Given this list of marker genes Chrna4, Chrna7, Chrne, Chrnb2, here is a description of the gene set: part of: Neurotransmitter receptors and postsynaptic signal transmission studied in species Mus musculus electronically inferred by orthology from the curated human pathway Reactome Pathway: Acetylcholine binding and downstream events This event has been computationally inferred from an event that has been demonstrated in another species.<p>The inference is based on the homology mapping from PANTHER. Briefly, reactions for which all involved PhysicalEntities (in input, output and catalyst) have a mapped orthologue/paralogue (for complexes at least 75% of components must have a mapping) are inferred to the other species.